The following is a description of a gene set: studied in species Mus musculus from publication Chen Y, Wang X (PMID 31504780) Genes predicted to be targets of miRBase v22 microRNA mmu_miR_7052_5p in miRDB v6.0 with MirTarget v4 prediction scores > 80 (high confidence targets). Mouse Gene Set: MIR_7052_5P, and this is the list of marker genes: Atp1b1, Hpcal4, Dgat2l6, Cplx2, Gm14744, Taok1, D7Ertd443e, Eya1, Pdk4, Gas8 (NCBI Gene Id 83455), Zfp536 (NCBI Gene Id 78852), Prkacb, Uhrf2, Prpsap2, Gli3, Chic1, Unk, Pabir2, Nudcd1, Efna5, Map1b, Cdon, Zfp174, Tbp (NCBI Gene Id 21374), Edar, Kat6a, Lyve1, Rap1gds1 (RAP1, GTP-GDP dissociation stimulator 1), Plpp6, Palb2, Pias2, Cdk5, Psmd3, Tpk1, Fam32a, Ccl20, Slc5a2, Fam178b (family with sequence similarity 178, member B), Casp2 (NCBI Gene Id 12366), Rasa1, Lypla2, Prss3b, Zfp710, Sv2b, Golph3, Ube2w, Prep, Adgre4, Surf2, Ap1g1, Slc35f2, Zfp189, Tnfaip1, Idh3b, Polr3k, Reln, Scrg1, Chrnb3, Lats2, Tek, Epb41l4a, Hddc3, Spata17, Riok1, Lrrc4c, Dgkg, Zfp207, Nanp, Dnajb13, Cbr3, Atp11c, Odad3, Gas7, Pappa, Ddn, Acp3, Dhx9, Slc41a3, Slc9a9, Ralgps2, H2-M5, Cdk7, Ube2h, Btaf1, Stmn3, Paqr9, Nalcn, Dlgap3, Hltf, Nts, Klf12, 5430402E10Rik, Emcn, Rasgef1b, Pde3a (NCBI Gene Id 97334), Atrn, Hnrnpa3, Fgfr3, Zmiz1